The following is a description of a gene set: Human Gene Set: GOBP_POSITIVE_REGULATION_OF_CYTOKINE_PRODUCTION_INVOLVED_IN_INFLAMMATORY_RESPONSE studied in species Homo sapiens Any process that activates or increases the frequency, rate or extent of cytokine production involved in inflammatory response., and this is the list of marker genes: STAT3, CLEC7A, IL17A, TLR3, IL6, PLA2G3, IL17RC, MYD88, HIF1A, GBP5, GPSM3, MIR17, IL17D, APPL1, TNF, IL17F, MIR21, IL17RA, MIR324, CARD9, IRF3, TLR4, NOD2, IL17B, TICAM1, MIR675, MAPK9, KPNA6, TLR6, CD6 (CD6 molecule)